Given this list of marker genes PDGFRB, FGFR1, TEK, CD8A, PTPRG, MUSK, ADRB2, CD8B, POU4F2, EDN2, EPHA4, EPHB1 (NCBI Gene Id 2047), EPHB2, PDGFRA, EPHA2, PAX6, DDR2, ROR1, NTRK2, CD4, IGF2, BDKRB2, NRG1, CYP1B1, KIT, DOK1, ERBB2, here is a description of the gene set: Genes in the cancer module 200. Human Gene Set: MODULE_200 studied in species Homo sapiens